The following is a description of a gene set: Human Gene Set: GERY_CEBP_TARGETS CCAAT/enhancer-binding proteins (C/EBPs) are a family of transcription factors that regulate cell growth and differentiation in numerous cell types. To identify novel C/EBP-target genes, we performed transcriptional profiling using inducible NIH 3T3 cell lines expressing 1 of 4 members of the C/EBP family. Functional analysis revealed a previously unknown link between C/EBP proteins and circadian clock genes. Our microarray data showed that the expression levels of 2 core components of the circadian network, Per2 and Rev-Erbalpha, were significantly altered by C/EBPs. Recent studies suggested that Per2 behaves as a tumor suppressor gene in mice. Therefore, we focused our additional studies on Per2. We showed that Per2 expression is up-regulated by C/EBPalpha and C/EBPepsilon. Per2 levels were reduced in lymphoma cell lines and in acute myeloid leukemia (AML) patient samples. In addition, we generated stable K562 cells that expressed an inducible Per2 gene. Induction of Per2 expression resulted in growth inhibition, cell cycle arrest, apoptosis, and loss of clonogenic ability. These results suggest that Per2 is a downstream C/EBPalpha-target gene involved in AML, and its disruption might be involved in initiation and/or progression of AML. from publication Gery S, Gombart AF, Yi WS, Koeffler C, Hofmann WK, Koeffler HP (PMID 15985538) studied in species Mus musculus Genes changed in NIH 3T3 cells (embryonic fibroblast) by expression of one or more of C/EBP proteins: CEBPA, CEBPB, CEBPG, and CEBPD., and this is the list of marker genes: C3, CD68, CLU, GIPC2, MVD, DYNLT2, PEA15, IFRD1, BTG2, SERPINB2, LYZ, POSTN, NSDHL, TMEM45A, GREM2, DBP, NGF, CD1D, TFRC, CRABP2, USP17L24, ALDH3A1, ECHS1, GLA, DDIT3, KLF4, ELOVL6, TGM3, LSS, S100A8, GADD45B, SERPINI1, HMGCR, ELMOD3, MKNK2, SH3GL3, FOXG1, DUSP1, BAIAP2, ID2, IER2, H2AC18, HP, ABHD5, CHORDC1, SSR1, PPARG, ZFAND2A, XDH, ATF3, HGF, HMOX1, GCH1, HGSNAT, ACTA2, HSPH1, GADD45G, GML, NXPH2, DCN, DNAJB9, RRAD, HIPK1 (NCBI Gene Id 23323), HTATIP2, PYHIN1, PLAUR, EIF1AX, MAFK, DNAJB2, NR1D1, PRNP, KNG1, CD47, CXCL6, TRIB3, IGF2, HSPA1A, EREG, HBEGF, PTX3, ANK3, LCN2 (NCBI Gene Id 3934), FGF7, RNH1 (NCBI Gene Id 6050), H3C1, SLFN12, RNASE3, TNFAIP6, ANGPTL4, BCKDHB, TGOLN2, IFI16, APBB1IP, ABCD2, ID3, H2BC4, HSPA1B, SAT1, FAM9A, NUS1, PPP1R15A, RGS2 (NCBI Gene Id 5997), ACSL1, DNAJB1, RDH11, RASL11B, LPL, BAG3, FOS, PLAT, SERPINB9, LPGAT1, PIM1, FHL2, VCAN, GSDME, WFDC21P, ORM1, CAPRIN2, JUNB, FOXF2, S100A3, ABCA1, PER2, GLRX, GPCPD1, CYB5R1, ADSS1, TOM1L1, WWC1, PROCR